Given this list of marker genes LGALS7, PVR, PKP1, ADRA2C, TMOD2, C11orf96, KLF3, PIP5K1A, OR4E1, SOX5, RNF19B, SERPINB2, ALDH1A3, SH3RF1, NPPB, CGREF1, SELPLG, COL18A1, CLCF1, STK10, ADRA2A, TSLP, CRISP3, OAS1, here is a description of the gene set: Genes changed by expression of activated form of HRas in MEF cells (embryonic fibroblast) with or without p65/c-Rel complex. Human Gene Set: HANSON_HRAS_SIGNALING_VIA_NFKB studied in species Mus musculus Extensive data indicate that oncoproteins, such as oncogenic H-Ras, initiate signal transduction cascades that ultimately lead to the activation of specific transcription factors. We and others have previously demonstrated that Ras activates the inherent transcriptional activation function of the transcription factor nuclear factor kappaB (NF-kappaB). Supportive of the importance of NF-kappaB in transformation, Ras-induced cellular transformation can be suppressed by expression of IkappaBalpha, an inhibitor of NF-kappaB, or by dominant-negative forms of the upstream activator IkappaB kinase (IKK). However, conclusive evidence for a requirement for NF-kappaB subunits in oncogenic transformation has not been reported. Furthermore, there is little understanding of the gene targets controlled by NF-kappaB that might support oncogenic conversion. The data presented here demonstrate that, although both p65 and c-Rel enhance the frequency of Ras-induced cellular transformation, these NF-kappaB subunits are not essential for Ras to transform spontaneously immortalized murine fibroblasts. Microarray analysis identified a set of genes induced by Ras that is dependent on NF-kappaB for their expression and that likely play contributory roles in promoting Ras-induced oncogenic transformation. from publication Hanson JL, Hawke NA, Kashatus D, Baldwin AS (PMID 15492243)